Given this list of marker genes SDC2, GLB1L2, HPSE, NAGLU, GPC5, IDUA, HPSE2, GPC2, GPC1, GLB1L3, GUSB, GLB1, GPC6, IDS, AGRN, SDC3 (NCBI Gene Id 9672), SDC4, SDC1, HGSNAT, GPC3, SGSH (NCBI Gene Id 6448), HSPG2, GLB1L, GPC4, here is a description of the gene set: HS-GAG degradation studied in species Homo sapiens Human Gene Set: REACTOME_HS_GAG_DEGRADATION